The following is a description of a gene set: Flat face Absence of concavity or convexity of the face when viewed in profile. Human Gene Set: HP_FLAT_FACE species: Homo sapiens, and this is the list of marker genes: B4GALT7, PEX16, FGFR2, HSPG2, SUMF1, ALG2, ABCC9, COL11A2 (NCBI Gene Id 494120), EHMT1, TMEM70, PAICS, PPP2R3C, COL2A1, CCBE1, SOX9, UBAP2L, CTNND1, DCPS, GUSB, GLB1, RAD21, GNPTAB, ROR2, MYH3, DNMT3B, MAPRE2 (microtubule associated protein RP/EB family member 2), ADAMTS3, PAK3, PEX11B, EFEMP2, KIAA0753, CCN2, CDCA7, PPP1R12A, UHRF1, COL9A1, KAT5, PLOD3, PRMT7, FN1 (fibronectin 1), DEAF1, SLC39A8, FGFR3, PEX14, BPNT2, FAT4, DVL1, GPC6, COL9A2, PEX5, PEX10, EP300, PAX3, COL3A1, RNU4-2, TAPT1, COL9A3, PTCH1, ATP6V0A2 (ATPase H+ transporting V0 subunit a2), WNT5A, PEX12, PEX13, ATRX, EBP, CDH1 (cadherin 1), RAB5IF, BRPF1, COL11A1, HELLS (helicase, lymphoid specific), PEX26, PDE4D, B3GALT6, MN1, LONP1, PEX6, GAD1, MAN2B1, AMER1, CREBBP, B3GAT3, CDH11, PRKAR1A, CAMK2G, PEX19, PEX7, ZBTB24, FLNA, TMCO1, TWIST1, MAF, SLC35B2, SMC3, AMMECR1 (NCBI Gene Id 9949), SMARCA2, FLNB, TUBB, PEX1, MATN3, FBXO31, PEX2, TBX22, KIF22, TRIP11, PEX3, SLC26A2, XYLT1, KMT2A, CHST3 (carbohydrate sulfotransferase 3)